The following is a description of a gene set: studied in species Mus musculus Mouse Gene Set: GOMF_BETA_GALACTOSIDASE_ACTIVITY Catalysis of the hydrolysis of terminal, non-reducing beta-D-galactose residues in beta-D-galactosides., and this is the list of marker genes: Glb1l, Glb1, Gm1110, Glb1l3, Glb1l2